Given this list of marker genes ZIC2 (NCBI Gene Id 7546), DCC, FLRT3, STAG2, PROK2 (prokineticin 2), FGF17, MAGEL2, TGIF1, SMC1A, SIX3, GLI2, IL17RD, SIM1, SHH, SPRY4, FOXH1, STIL, SMARCB1, CHD7, ANOS1, NDNF, TRAF7, PIK3CA, CCDC141, PTCH1, WDR11 (NCBI Gene Id 79207), FGF8, SUFU, CDON, HS6ST1, NF2, SMO, CRIPTO, AKT1, SEMA3A, NODAL, FEZF1, DUSP6, SOX10, TACR3, PROKR2, TRH (thyrotropin releasing hormone), DLL1, BAP1, PDGFB, LHX3, PLCH1, SMARCE1, TERT, GAS1, HESX1, DISP1, FGFR1, here is a description of the gene set: An abnormal functionality of the hypothalamus. Abnormal hypothalamus physiology Human Gene Set: HP_ABNORMAL_HYPOTHALAMUS_PHYSIOLOGY studied in species Homo sapiens